The following is a description of a gene set: Human Gene Set: GOBP_GLYCINE_BIOSYNTHETIC_PROCESS The chemical reactions and pathways resulting in the formation of glycine, aminoethanoic acid. species: Homo sapiens, and this is the list of marker genes: SHMT2, AGXT2, SHMT1, HAO1, AGXT